The following is a description of a gene set: Genes predicted to be targets of miRBase v22 microRNA hsa-miR-630 in miRDB v6.0 with MirTarget v4 prediction scores > 80 (high confidence targets). from publication Chen Y, Wang X (PMID 31504780) Human Gene Set: MIR630 species: Homo sapiens, and this is the list of marker genes: ZBTB4, TMEM170A, RASGEF1A (NCBI Gene Id 221002), RFESD, DCAF13, AIG1, CRKL, DCTN4, NKTR, HYCC2, LRRC1, WASHC4, PHIP, SUCLA2, LAPTM5, CDC7, ZDHHC21, ZNF148, SLC51A, PSMC2, LYPD6, ANKMY2, ZNF131, SLITRK3, KDM3B, LMO3, ERO1B, NDUFA5, SAMD12, GOLIM4, AKAP10, ZFP1, YES1, CHD9, EFCAB5, FRS2, EXO1, ZDHHC15, CLIC2 (chloride intracellular channel 2), H3-3B, MED13L, CBX5, KBTBD2, TMED7, RPF2, PDP1, DIPK2A, ST6GAL2, RDH10, KIF13A, GPR4, PCLO, ZNF17 (NCBI Gene Id 7565), KLF6, DDIAS, NAB1, CTDSPL2, TLK2, ABCC2, CEP44, PRKCI, MIA3, PDLIM5, LUC7L3, WWOX, EZH2, SLCO1B1, SALL3, EPC1, CFLAR, SMIM15, TM7SF3, MTM1, SLC10A7, NHS, ARL6, CCDC71L, TAPBPL, QKI, AMER2